Given this list of marker genes SIGLEC10, RHPN2, GOT1, TMEFF2, SEPTIN3, COX15, KIAA0408, TSPAN6, RUSC1, IDI2, GPC6, CTBP2, PDK3, PIP4K2A, STK17A, MTCL3, NEXMIF, MYF5, ZNF236, NDC1, HOOK3, CSGALNACT2, BCO2, SMAD2, DCLK3, PRDM16, ESR1, SHPRH, ITGAE, VSNL1, ZNF704, SKP1, CDK19, KRT222, PER1, IQCK, USP48, NRF1, YWHAQ, C11orf58, ETNK1, LIAS (lipoic acid synthetase), GCSAM, RHAG, PLEKHS1, MTCL2, APOBEC3F, CLIP3 (CAP-Gly domain containing linker protein 3), CBX2, GPBP1L1, C2orf88, EIF4EBP2, OST4, YWHAZ, PPM1F, SULT1C2, MYO1A, ACMSD, NMBR, MEX3C, PSMC4, TMPRSS11A, AP1G2, SLITRK6 (SLIT and NTRK like family member 6), CEP20, GZF1, here is a description of the gene set: from publication Chen Y, Wang X (PMID 31504780) Genes predicted to be targets of miRBase v22 microRNA hsa-miR-3122 in miRDB v6.0 with MirTarget v4 prediction scores > 80 (high confidence targets). studied in species Homo sapiens Human Gene Set: MIR3122